The following is a description of a gene set: Human Gene Set: GSE5542_UNTREATED_VS_IFNA_AND_IFNG_TREATED_EPITHELIAL_CELLS_6H_UP studied in species Homo sapiens Type I and type II interferons (IFNs) bind to different cell surface receptors but activate overlapping signal transduction pathways. We examined the effects of a type I IFN (IFN-acon1) and a type II iFN (IFN-g1b) on gene experession in A549 cells and demonstrate that there is a common set of genes modulated by both IFNs as well as a set of gene specifically regulated by each, reflecting the activation of different signaling pathways. In particualr, IFN-g induced many more genes of the signaling pathways, apoptosis, and cytokine interactions than did IFN-a. Even with genes induced by both IFNs there were distinctive quantitativive differences in expression. IFN-g1b plays a major role in the induction and regulation of the complement pathway. Previous work has shown a synergistic antivral and antiproliferative effect of type I and type II IFNs in cell culture and in the treament of tumors in mice. We demonstrate that a majority of genes showed and additive effect of IFN-acon1 and IFN-g1b, but a subset of gene is synergistically induced; these incluce ISG10, MX2, OAS2, and other genes known to be involved in the antiviral response, TRAIL (TNFSF10) and caspases involved in apoptosis and chemokine genes RANTES, CXCL10, and CXCL11. Greater than additive transcription of some of these genes in the presence of both IFNs was confirmed by real-time kinetic RT-PCR. Elevated induction of many of these genes may be sufficient to explain the synergistic antiviral and antitumor effects of this combination of IFNS in vivo. Genes up-regulated in epithelial cells (6h): untreated versus interferon alpha and IFNG. from publication Sanda C, Weitzel P, Tsukahara T, Schaley J, Edenberg HJ, Stephens MA, McClintick JN, Blatt LM, Li L, Brodsky L, Taylor MW (PMID 16800785), and this is the list of marker genes: INSL4, GALT, SFXN1, TESPA1, BTF3, NBEA, DLL3, FHIT, TRABD2A, ABCA7, TMEM120B, H2BC18, ATP6V0E2, SPTBN1 (spectrin beta, non-erythrocytic 1), SMAP2, SYNE3, LEF1, ELP2, TTTY10, THBS4, TAF9B, CNST, FABP7, TSPAN18, TPP2, TMEM201, DAPP1, NFRKB, METAP1D (methionyl aminopeptidase type 1D, mitochondrial), TNNC1, TCP11L2, BEND5, ECE1, ACVR2A, SFMBT1, RIC3, IGSF9B, ABCC2, DSC1, LRRC8C, FANCD2, WWP1, NUDT11, MAN1C1, GPA33, OR1E1, FAAH2, ADGRE4P, ANKRD16, CYP4Z2P, CRTC3, SERPINE2, LEPROTL1 (leptin receptor overlapping transcript like 1), SCGB2A1, WNT7A, ACTN1, MYCBP2 (MYC binding protein 2), PTPN6, HINT1, HMGB3P22, ADGRE1, MSL3B, SHLD1, RPL13AP20, ZSWIM1, UBQLN2, AKAP1, HAVCR1, ATP11C, TAPT1, IL4R, IFT57, MT1L, MAL, PHF19 (PHD finger protein 19), TIMD4, TTC27, LAMTOR5, RNF138, MSL3 (MSL complex subunit 3), LGALS14, PPWD1 (NCBI Gene Id 23398), MATCAP2, ZNF793, RIPOR2, CALD1, NAP1L4, RGMB, KLHL3, SESN3, MYB, C7orf33, KLF3-AS1, FOXP1, EIF3A, ABRAXAS1, RASSF3, DMXL2, IL6ST, LDHB, ICOS, TCEA3, PIR, TPCN1, PALM3, NDUFAF7, MRPL32, IL6R (interleukin 6 receptor), CDC25B, PMS2CL, OR4Q3, MAT2A (methionine adenosyltransferase 2A), CDH1, EIF1AY, SEMA4C, RNFT2, PCYOX1L, NUDCD2, ZBTB18, KCNQ1, COTL1 (NCBI Gene Id 90755), NACA4P, CDCA7L, NLRP3, AP1G2, WBP11P1, NEK6, RPL13AP3, ADPRM, GRAP, SLC40A1, MAP3K1, CHN1, CEP68, ASAP1, MINDY1, NPAT, H4C13, SNED1, MDN1, SGTB, DNAJC30, AKR1E2, MRPS24, APOBEC4, RMND5B, TLK1, ZNF506, UBQLN1, TMEM45B, NELL2, CHMP7, RASA3, MIR16-2, RPUSD4, SORBS3, DNAJA4 (DnaJ heat shock protein family (Hsp40) member A4), ITPKB, ATXN7L1, PTK2, MTHFD1, DIPK1A, TNFRSF10D, GLB1L3, ANKRD26, CAMSAP2, OR2L8, NSUN5, ZNF215, OR1F2P, AEN (NCBI Gene Id 64782), WDR81, AXIN2, DGKA, CD55, PFKM, CARMIL1, SLC26A11, FMNL2, KCNJ5-AS1, MCCC2, PKHD1L1, SELL, ZMYM3, HAPLN3, UXS1 (NCBI Gene Id 80146), SULT1B1, HSF5, OGDH, FLVCR2, LRRN1, ANKRD18B, GOLGA7B, TTF2, LDLRAP1 (low density lipoprotein receptor adaptor protein 1), TSHR, ZC3H12D, MORC2